The following is a description of a gene set: The acquisition, loss or modification of a protein or lipid within a low-density lipoprotein particle, including the hydrolysis of triglyceride by hepatic lipase, with the subsequent loss of free fatty acid, and the transfer of cholesterol esters from LDL to a triglyceride-rich lipoprotein particle by cholesteryl ester transfer protein (CETP), with the simultaneous transfer of triglyceride to LDL. studied in species Mus musculus Mouse Gene Set: GOBP_LOW_DENSITY_LIPOPROTEIN_PARTICLE_REMODELING, and this is the list of marker genes: Mttp, Pla2g2e, Abcg1, Apoe, Pla2g5, Lipc, Apoa2, Pla2g12b, Pla2g3, Pla2g10, Mpo, Pla2g7, Apob